Given this list of marker genes ANGPTL3, APOA4, APOC2, CLSTN3, CPT1A, FUT1, IL1B, APOA2, PRKCD, ABCD2, ABCD1, PRKCE, PLIN5, APOA5, AADAC, PPARA, MTLN, ABHD5, DAGLB, ENPP7, AKT2, TWIST1, IRS1, SCT, PNPLA2, ADORA1, IRS2, here is a description of the gene set: Human Gene Set: GOBP_POSITIVE_REGULATION_OF_LIPID_CATABOLIC_PROCESS species: Homo sapiens Any process that activates or increases the frequency, rate or extent of the chemical reactions and pathways resulting in the breakdown of lipids.